The following is a description of a gene set: species: Mus musculus Mouse Gene Set: GOBP_PEPTIDYL_PROLINE_MODIFICATION The modification of peptidyl-proline., and this is the list of marker genes: Ppif, Nktr, Ero1a, Ppwd1, Ppib, Ppih, P4hb, Ogfod1, Ppic, Egln2, Ppig, Ppihl, Crtap, Pin1, Ppia, Fkbp10, Ppid, Prdx4, Ppil1, P4ha1, Ero1b, P4ha2, Ntmt1, P3h2, Ppie, Pin1rt1